The following is a description of a gene set: Familial hyperlipidemia type 5 Human Gene Set: WP_FAMILIAL_HYPERLIPIDEMIA_TYPE_5 species: Homo sapiens, and this is the list of marker genes: SEL1L, GPIHBP1, LDLR, CETP, LCAT, LMF1, APOC2, LPL, PLTP, APOA2, APOA5, LIPC, APOA1, APOA4, LRP1